Given this list of marker genes Hdac7, Nsmce2, Phc1, Pias4, Cbx8, Brca1, Nup205, Nup85, Nsmce4a, Tdg, Nup54, Nup93, Smc6, Seh1l, Mdc1, Cbx4, Nsmce3, Xpc, Nup58, Ndc1, Eid3, Rad52, Nsmce1, Smc3 (structural maintenance of chromosomes 3), Bmi1, Nup210, Nup133, Scmh1, Nup155, Cbx2, Ring1, Rae1, Blm, Rpa1, Rad21, Aaas, Rnf168, Nup42, Sumo1, Pcgf2, Stag1, here is a description of the gene set: This event has been computationally inferred from an event that has been demonstrated in another species.<p>The inference is based on the homology mapping from PANTHER. Briefly, reactions for which all involved PhysicalEntities (in input, output and catalyst) have a mapped orthologue/paralogue (for complexes at least 75% of components must have a mapping) are inferred to the other species. electronically inferred by orthology from the curated human pathway studied in species Mus musculus Reactome Pathway: SUMOylation of DNA damage response and repair proteins part of: SUMO E3 ligases SUMOylate target proteins